The following is a description of a gene set: from publication Lein ES, Hawrylycz MJ, Ao N, Ayres M, Bensinger A, Bernard A, Boe AF, Boguski MS, Brockway KS, Byrnes EJ, Chen L, Chen L, Chen TM, Chin MC, Chong J, Crook BE, Czaplinska A, Dang CN, Datta S, Dee NR, Desaki AL, Desta T, Diep E, Dolbeare TA, Donelan MJ, Dong HW, Dougherty JG, Duncan BJ, Ebbert AJ, Eichele G, Estin LK, Faber C, Facer BA, Fields R, Fischer SR, Fliss TP, Frensley C, Gates SN, Glattfelder KJ, Halverson KR, Hart MR, Hohmann JG, Howell MP, Jeung DP, Johnson RA, Karr PT, Kawal R, Kidney JM, Knapik RH, Kuan CL, Lake JH, Laramee AR, Larsen KD, Lau C, Lemon TA, Liang AJ, Liu Y, Luong LT, Michaels J, Morgan JJ, Morgan RJ, Mortrud MT, Mosqueda NF, Ng LL, Ng R, Orta GJ, Overly CC, Pak TH, Parry SE, Pathak SD, Pearson OC, Puchalski RB, Riley ZL, Rockett HR, Rowland SA, Royall JJ, Ruiz MJ, Sarno NR, Schaffnit K, Shapovalova NV, Sivisay T, Slaughterbeck CR, Smith SC, Smith KA, Smith BI, Sodt AJ, Stewart NN, Stumpf KR, Sunkin SM, Sutram M, Tam A, Teemer CD, Thaller C, Thompson CL, Varnam LR, Visel A, Whitlock RM, Wohnoutka PE, Wolkey CK, Wong VY, Wood M, Yaylaoglu MB, Young RC, Youngstrom BL, Yuan XF, Zhang B, Zwingman TA, Jones AR (PMID 17151600) Molecular approaches to understanding the functional circuitry of the nervous system promise new insights into the relationship between genes, brain and behaviour. The cellular diversity of the brain necessitates a cellular resolution approach towards understanding the functional genomics of the nervous system. We describe here an anatomically comprehensive digital atlas containing the expression patterns of approximately genes in the adult mouse brain. Data were generated using automated high-throughput procedures for in situ hybridization and data acquisition, and are publicly accessible online. Newly developed image-based informatics tools allow global genome-scale structural analysis and cross-correlation, as well as identification of regionally enriched genes. Unbiased fine-resolution analysis has identified highly specific cellular markers as well as extensive evidence of cellular heterogeneity not evident in classical neuroanatomical atlases. This highly standardized atlas provides an open, primary data resource for a wide variety of further studies concerning brain organization and function. Mouse Gene Set: LEIN_MEDULLA_MARKERS Top 100 ranked genes most specific to medulla (myelencephalon) hindbrain region of adult mouse brain. species: Mus musculus, and this is the list of marker genes: Clgn, Lyve1, Kcnab2, Phf20, Serpinb1b, Crot, Vegfb, Klhl36, Gas2, Mafg, Pikfyve, Tat, Serpinb1c, Capn1, Kcng4, Minar1, Hoxc4, Serpina3k, Glra4, Adipor2, Fbln7, Abhd8, Anxa5, P2ry14, P2rx6, Anxa2, Slc34a1, Slc6a9, Lhx5, Acbd3, Slc26a6, Nsdhl, Ublcp1, Glra1, Nrg1, P2rx5, Ufc1, Sv2c, Entpd3 (ectonucleoside triphosphate diphosphohydrolase 3), Ldlr, Cd151, Slc17a6, Panx2, Spp1, Kank4, Slc45a3, H2-Eb1, Myc, Dlk1, Hmga1, Pmp22, Asah2, Cct8, Adgre5, Steap2, Marchf2, Tnks, Eif5a2, Ppp2r2b, Kcnj14, Eaf1, Prdx1, Cd59a, Wnt8b, Rassf4, Hoxb6 (homeobox B6), Phlda3, Pcsk6 (NCBI Gene Id 97406), Ankrd35, Esrrg, Gpr101, Glrx3, Map3k20, Hars2, Trip10, Lrrc27, Cyp4f16, Chrnb4, Ankrd55, Mrap2, Fzd8, Fstl1, Slc6a5, Vcf2, Ar, Efcab3, Fnta